Given this list of marker genes Exo5, Isg20, Exd2, Pld4 (NCBI Gene Id 217885), Pole, Exo1, Meiob, Polg, Pld3, Mgme1, here is a description of the gene set: Catalysis of the sequential cleavage of mononucleotides from a free 5' or 3' terminus of a single-stranded DNA molecule. Mouse Gene Set: GOMF_SINGLE_STRANDED_DNA_EXODEOXYRIBONUCLEASE_ACTIVITY species: Mus musculus